The following is a description of a gene set: from publication Miyagawa Y, Okita H, Nakaijima H, Horiuchi Y, Sato B, Taguchi T, Toyoda M, Katagiri YU, Fujimoto J, Hata J, Umezawa A, Kiyokawa N (PMID 18212050) Ewing's family tumor (EFT) is a rare pediatric tumor of unclear origin that occurs in bone and soft tissue. Specific chromosomal translocations found in EFT cause EWS to fuse to a subset of ets transcription factor genes (ETS), generating chimeric EWS/ETS proteins. These proteins are believed to play a crucial role in the onset and progression of EFT. However, the mechanisms responsible for the EWS/ETS-mediated onset remain unclear. Here we report the establishment of a tetracycline-controlled EWS/ETS-inducible system in human bone marrow-derived mesenchymal progenitor cells (MPCs). Ectopic expression of both EWS/FLI1 and EWS/ERG proteins resulted in a dramatic change of morphology, i.e., from a mesenchymal spindle shape to a small round-to-polygonal cell, one of the characteristics of EFT. EWS/ETS also induced immunophenotypic changes in MPCs, including the disappearance of the mesenchyme-positive markers CD10 and CD13 and the up-regulation of the EFT-positive markers CD54, CD99, CD117, and CD271. Furthermore, a prominent shift from the gene expression profile of MPCs to that of EFT was observed in the presence of EWS/ETS. Together with the observation that EWS/ETS enhances the ability of cells to invade Matrigel, these results suggest that EWS/ETS proteins contribute to alterations of cellular features and confer an EFT-like phenotype to human MPCs. Genes commonly down-regulated in UET-13 cells (mesenchymal progenitor) by expression of EWSR1 fusions with ETS transcription factors FLI1 and ERG. studied in species Homo sapiens Human Gene Set: MIYAGAWA_TARGETS_OF_EWSR1_ETS_FUSIONS_DN, and this is the list of marker genes: COL5A1, ADAM12, RPS6KA6, CHI3L1, CHST7, SBF2-AS1, TRBC2 (NCBI Gene Id 28638), PCDH18, C10orf90, SEMA5A, CCDC80, HACD1, TCAF1, ITGA11, IGFBP3, VSTM4, ALDH1A3, LINC01118, HSPB7, TNFRSF19, MATN2, ASS1, CHN1, AMIGO2, PLPP3, HMGA1, SPOCD1, EYA4, PRDM1, EGFR, ZNF395, PPP2R3A, FOXD1, CMKLR2, DIPK2A, PRR16, LTBR, CREG1, ADM, GAPLINC, LINC00968, NRG1, GPR180, KRTAP1-5 (NCBI Gene Id 83895), GRIA1, PLOD2, SOAT1, MME, AFF3, VASN, CD44, COL8A1, LUM, GPNMB, MIR1245A, DMXL2, MAB21L2, SYNC, EREG, CAMK2D, ATP7A, FILIP1L (NCBI Gene Id 11259), OSBPL1A, TRBC1, TSPAN5, PLPP4, VGLL3, LSM11, NR2F2, RIOK1, F3, CALM2, ABHD2, PABPC1L, TENM3, ZNF365, NREP, TAF13, ACTRT3, SRPX, ARL15, HAS2, DKK1 (NCBI Gene Id 22943), BMERB1, SPRED1, ZNF239, DNM3OS, FIBIN, DENND1B, MEIS2, SEMA7A, ELOVL6, PRSS12, MOSPD1, ARHGAP1, CDC42EP3, COL3A1, IL1R1, DCBLD2, GALNT5, NRIP1, SMAD7, MINDY2, TNFRSF11B, RAB27A, SNX21, SNX9, RBMS3, PKIA, GCNT1, PPP1R7, SVIL, LTBP1, SEMA3C, VCAN, TBX2-AS1, NR3C1, TANC2, SEC63, NID2, MAFF, COL11A1, LYPD6B, ADAM19, PDE1C, FAM171B, STC1, SLC8A1, SOWAHC, SLC16A7, ARHGEF5, STC2, CEP135, B3GNT9, DNER, ARHGEF28, HIP1, TMEM171, IRS1, CA12, COL1A2, EIF5A2, LIF, PTGER2, INKA2, SPEG, NABP1, AK5, RGMB, APCDD1L, ST3GAL6, AKR1C1, MIR221, RECK, ITGB8, MAP2, CXCL8, TNIK, PDLIM4, MIR155HG (NCBI Gene Id 114614), TBX2, SLC4A7, DAB2 (NCBI Gene Id 1601), ZNF281, FIBCD1, SERTAD2, DOK5, HYCC1, ELL2, MARCKS, OSMR, ADAMTS5, ADAMTS12, PRICKLE2, GATA6, CEMIP, LMCD1, AK4, SLC2A3, HMGA2, BNIP3, MFSD2A, RFTN1, CCL3, ACTN1, ACTG2, INPP4B (NCBI Gene Id 8821), UNK, SERPINB7, MMP14, ANGPT1, PLAU, NEDD4L, LRRC17, TLE1, CCL2, PLXNA1, GFPT2, GLT8D2, ADAMTSL1, PID1, CA9, GASK1B, QSOX1, MICAL2, SLC22A23, ENPP2, BAALC, SH3BP5, FAM174A, CLCF1, NUDT7, ABHD17B, LOXL2, DIPK1A, EHBP1, RPS6KA2, FST, TMEM158, SPARC, KCTD4, STXBP5, PRRX1, SLC1A3, HR, FGF7, SCG5, SEC24D, SYNM, NRP1, NAP1L1, PEX2, SMIM29, PDZRN3, IL6